Given this list of marker genes LIPC, APOA1, HMGCS2, PRKAA2, STARD4, IDH3B, ABCA1, MIR30C1, APOA4, FDPS (NCBI Gene Id 2224), CYP11A1, KPNB1, GBA1, CYP7B1, MIR548P, LEPR, MIR27B (NCBI Gene Id 407019), MIR98, SNX17, OSBPL5, GBA2, NPC1, PMVK, PIP4P1, GPR146, APOL2, NSDHL, AGT, ERLIN2, PRKAA1, FECH, C7orf50, SEC14L2, SULT1C3, AQP8, ACLY, CAT, IL4, LIPE, DGKQ, PRKACA, EBP, AGTR1, SULT2B1, CYB5R3, CLN6, SOAT2, G6PD, IDH2, MIR342, APOB, ERLIN1, HMGCR, DGAT2, STARD3, CYP51A1, CYP46A1, UGT1A4, GNB3, LBR, SCAP, PON1, LMF1, MVD, APOE, AKR1D1, PCSK9, ABCA5, APOBR, SCARF1, IDH3A, MBTPS1, CH25H, SULT2A1, SREBF2, CYP2R1, TSKU (tsukushi, small leucine rich proteoglycan), TM7SF2 (NCBI Gene Id 7108), APOL1, NFE2L1, IDI1, ABCA2, CYP39A1, LDLRAP1, LIPA, MBTPS2, VLDLR, CYP11B1, SC5D, FGF1, LEP, DHCR24, ANGPTL3, CYP2D6, CYP11B2, HSD17B7, PPARD, ACAA2, SOAT1 (sterol O-acyltransferase 1), NR1H4, CETP, CYP24A1, OSBPL1A (oxysterol binding protein like 1A), STAR, MSMO1, CUBN, LPCAT3, IDH1 (isocitrate dehydrogenase (NADP(+)) 1), LDLR, APOA5, MIR96, ACADL, IDI2, CYP7A1, SREBF1, CYP1A2, HMGCS1, INSIG1, CLN8, CYP27A1, PAQR3, MVK, UGT1A3, MIR185, ACADVL, PLPP6 (NCBI Gene Id 403313), NPC2, TTC39B, DISP3, APOA2, CYP27B1, FMO5, CEBPA, INSIG2, LSS, IDH3G, LRP5, SMPD1, ABCG4, SQLE, NR0B2, FDXR, EPHX2, SERPINA12, APOC1, NPC1L1, LIMA1, QKI (NCBI Gene Id 9444), GNAI1, MIR27A, FDFT1, FDX1, FGFR1, HDLBP, CFTR, ERRFI1, APOF, CYP2C9, CYP3A4, DHCR7, ARV1, LCAT, MAPK1, SCARB1, ABCG1, CES1, MIR182, here is a description of the gene set: The chemical reactions and pathways involving secondary alcohol. Human Gene Set: GOBP_SECONDARY_ALCOHOL_METABOLIC_PROCESS studied in species Homo sapiens